The following is a description of a gene set: The chemical reactions and pathways resulting in the formation of polyamines, any organic compound containing two or more amino groups. studied in species Homo sapiens Human Gene Set: GOBP_POLYAMINE_BIOSYNTHETIC_PROCESS, and this is the list of marker genes: PAOX, AZIN2, SAT2 (NCBI Gene Id 112483), SAT1, AMD1, AGMAT, AZIN1, SMOX, OAZ1, OAZ3, ODC1, SRM, OAZ2, SMS